Given this list of marker genes Creb3l1, Hdac2, Src, Ptpn1, Rrm2b, Vdac2, Cdkn2d, Ybx3 (NCBI Gene Id 56449), Pik3cb, Tpt1, Gcg, Muc1, Ackr3, Sod2, Bdkrb2, Map2k1, Nono, Hspb1, Bcl2l12, Syvn1, Mmp9, Wfs1, Fbxo7, Opa1, Bcl2l10, Eno1b, Nol3, Ndufa13, Sh3glb1, Fgf2, Snai1, Plaur, Tmbim6, Herpud1, Rack1, Rtkn2, Zfp385a, Parl, Pttg1ip, Triap1, Snai2, Akt1 (thymoma viral proto-oncogene 1), Bid, Ikbkg, Sirt1, Eif2ak3, Dnaja1, Fignl1, Hells, Fzd1, Ell3, Nfe2l2, Mdm2, Epo, Hdac1, Cep63, Bag5, Marchf7, Nme5, Cd44, Fyn, Hyou1, Atad5, Park7, Hif1a, Ppia, Ndufs3, Trap1, Noc2l, Ccar2, Bcl2l1, Armc10, Mdm4, Tmem161a, Cd74, Ctnnb1, Selenos, Kdm1a, Ern1, Ddx3x, Clu (NCBI Gene Id 28201), Lrrk2, Txndc12, Wnt1 (wingless-type MMTV integration site family, member 1), Usp47, Pink1, Ddias, Mif, Ivns1abp, Eno1, Pycr1 (NCBI Gene Id 209027), Bcl2, Prkn, Creb3, Kdm6a, Mapk7, D1Pas1 (DNA segment, Chr 1, Pasteur Institute 1), Rrn3, Mapk8ip1, Il10, Cxcl12, Gpx1, Ppif, G2e3, Pdx1 (pancreatic and duodenal homeobox 1), Ptgs2, Atf4, Grina, Gata4, Trim32, Eif2a, Xbp1, Uri1, here is a description of the gene set: Any process that stops, prevents or reduces the frequency, rate or extent of intrinsic apoptotic signaling pathway. Mouse Gene Set: GOBP_NEGATIVE_REGULATION_OF_INTRINSIC_APOPTOTIC_SIGNALING_PATHWAY studied in species Mus musculus